The following is a description of a gene set: Mouse Gene Set: GOBP_MUCOSA_ASSOCIATED_LYMPHOID_TISSUE_DEVELOPMENT The process whose specific outcome is the progression of mucosal-associated lymphoid tissue over time, from its formation to the mature structure. Mucosal-associated lymphoid tissue is typically found as nodules associated with mucosal epithelia with distinct internal structures including B- and T-zones for the activation of lymphocytes. studied in species Mus musculus, and this is the list of marker genes: Nkx2-3, Tcf3, Tox, Stat5a (signal transducer and activator of transcription 5A), Ada, Rorc, Artn, Ret, Cacnb4, Ikzf1, Foxl1, Id2, Stat5b